Given this list of marker genes Hhex, Top2b, Abl1, Top3b, Top3a, Ercc3, Top1mt, Recql, Top1, Top2a, Hmgb2, Hmgb1, Mterf1b, Blm, Hmgb3, Wrn, Mterf1a, Tdrd3, here is a description of the gene set: Mouse Gene Set: GOBP_DNA_CONFORMATION_CHANGE species: Mus musculus A cellular process that results in a change in the spatial configuration of a DNA molecule. A conformation change can bend DNA, or alter the, twist, writhe, or linking number of a DNA molecule.